Given this list of marker genes KLK7, DPEP2, DPEP1, LNPEP, MMP28, ADAMTS14, SPOCK2, CPB1, ADAMTSL2, ADAM2, YME1L1, NPEPPSP1, CPZ, XPNPEP1, PEPD, PMPCA, PAPPA, ADAM20, MATCAP2, ADAM28, LXN, MBTPS2, ADAMTS10, MMP26, SPOCK1, YBEY, COL4A3, ECE2, TIMP1, ADAMTS19, MMP1, TIMP3, MMP8, PSMD14, CNDP2, FOLH1B, MMP23B, UQCRC2, NRDC, ECEL1, ADAM22, TRABD2B (NCBI Gene Id 388630), MMP15, ADAMTS1, CLCA4, TRABD2A, ANPEP, ADAMTS17, ADAMTS8, TLL1, CPB2, ENPEP, MEP1A, MMP21, ADAMTS16, LMLN, ADAM11, MPND, RNPEPL1, PHEX, COPS6, PAPPA2, ADAMTS4, SPG7, MIPEP, BMP1, MYSM1, NPEPPS, MMP17, AMZ2, VASH1, CPA5, MMP13, CPE, AGBL4, MATCAP1, MMP3, CPM, OMA1, EIF3F, ADAMTS18, PRCP, NGF, XPNPEP3, LAP3, PREP, DPP3, MMP10, ADAM18, MMP16, ADAM7, STAMBPL1, RECK, MMP2, AGBL1, ADAMTS5, PMPCB, SPOCK3, ADAM8, NUDT16, PRPF8 (NCBI Gene Id 6108), SPRTN, CHMP1A, PITRM1, ADAM15, ADAM21, MMP7, ECE1, RARRES1, CPD, CPN1, TIMP2, FOLH1, DNPEP, ADAM10, RNPEP, ADAMTS20, TLL2, CPA3, MMP11, CLCA2, ADAM33, CLCA1, CIROP, ERMP1, CPQ, ZMPSTE24, MMP24, MMP27, ADAM12, ADAM29, RCE1, CPA1, BST2, ADAMTS3, ADAM23, ADAM19, ADAMTS13, NLN, CPA4, NAALAD2, ACE2, MME, CPXM1, ADAM32, AGTPBP1, ADAM30, MMEL1, METAP2, VASH2 (NCBI Gene Id 79805, vasohibin 2), CPA2, AGBL3, CPXM2, ADAMTS2, ADAMTS15, IDE, MMP25, BRCC3, ERAP2, AEBP1, ADAMTS6, STAMBP, ADAM17, MMP9, EIF3H, PSMD7, THOP1, ADAM9, AGBL5, CNDP1, AFG3L2, NPEPL1, LTA4H, MMP20, MMP19, ADAMDEC1, LVRN (NCBI Gene Id 206338), EEF1AKMT4-ECE2, AOPEP, FETUB, KEL, XPNPEP2, MEP1B, ADAMTS12, COPS5, METAP1D, PRSS2, AMZ1, NAALADL1, ATP23, MMP12, ERAP1, CPA6, TRHDE, TMPRSS6, CPO, AGBL2, ACE, METAP1 (methionyl aminopeptidase 1), ADAMTS7, ASTL, MMP14, TIMP4, ADAMTS9, here is a description of the gene set: Catalysis of the hydrolysis of peptide bonds by a mechanism in which water acts as a nucleophile, one or two metal ions hold the water molecule in place, and charged amino acid side chains are ligands for the metal ions. Human Gene Set: GOMF_METALLOPEPTIDASE_ACTIVITY species: Homo sapiens